The following is a description of a gene set: Genes down-regulated in SCLC (small cell lung cancer) cells with acquired resistance to ABT-737, an inhibitor of the BCL2 family proteins. Bcl-2 is a central regulator of cell survival that is overexpressed in the majority of small cell lung cancers (SCLC) and contributes to both malignant transformation and therapeutic resistance. We compared primary SCLC xenografts prepared from de novo human tumors with standard cell line-based xenografts in the evaluation of a novel and highly potent small molecule inhibitor of Bcl-2, ABT-737. ABT-737 induced dramatic regressions in tumors derived from some SCLC cell lines. In contrast, only one of three primary xenograft SCLC tumors showed significant growth inhibition with ABT-737. Explanations for this apparent dichotomy may include relatively low expression of Bcl-2 in the primary xenografts or inherent differences in the model systems. The addition of etoposide to ABT-737 in the primary xenografts resulted in significant decreases in tumor growth, underscoring the clinical potential of ABT-737 in combination therapy. To identify factors that may contribute to resistance to ABT-737 and related inhibitors, we isolated resistant derivatives of an initially sensitive cell line-based xenograft. Acquired resistance in this model was associated with decreases in the expression of the primary target Bcl-2, of proapoptotic partners of Bcl-2 (Bax and Bim), and of Bcl-2:Bim heterodimers. Expression profiling reveals 85 candidate genes demonstrating consistent changes in gene expression with acquired resistance. Taken together, these data have specific implications for the clinical development of Bcl-2 inhibitors for SCLC and broader implications for the testing of novel anticancer strategies in relevant preclinical models. Human Gene Set: HANN_RESISTANCE_TO_BCL2_INHIBITOR_DN species: Homo sapiens from publication Hann CL, Daniel VC, Sugar EA, Dobromilskaya I, Murphy SC, Cope L, Lin X, Hierman JS, Wilburn DL, Watkins DN, Rudin CM (PMID 18381439), and this is the list of marker genes: LITAF, KLK12, NELL1, RASAL1, SDC4, PRSS1, ASTN2, FZD9, HSPA1A, FOXA2, POU4F1, ASS1, POU4F2, BAMBI, MSX1, IGFBP5, PCK2, CEBPD, NCK2, GRP, TRIB3, FRAS1, PPIC, GUSBP2, LRATD2, CALML3, MGMT, PRSS3, IGSF21 (NCBI Gene Id 84966), COMTD1, TMT1A, CEL, NIBAN1, PRSS2, RHPN2, HSPB1, POMC, OTP, GALK1, ENO3, ATF5, GSTO1, DLK1, TESC, SYNGR4, SNTB1, SH3GL2, PAM